Given this list of marker genes NEPNP, ROBO1, ASCL1, PXT1 (NCBI Gene Id 222659), CLEC4E, LELP1, TAFA4, CPB2, RPS29, KCNT1, IGHG3, ADAMTS16, DIMT1, EGR3, CCDC7, FABP6, TRHR, BCL2L10, HCK, ZP2, UBE2DNL (ubiquitin conjugating enzyme E2 D N-terminal like (pseudogene)), RNF138, HPCAL4, RETREG1, LRFN2, MIR211, FGFR4, COL6A6, SOHLH2, GASK1B, PLIN5, LIPH, RANBP10, SUGT1, PLA2G3, ARL10, CFAP100, CXCR1, NIBAN3, CFI, AGMAT, ASTN2, MAT2B, DNAAF10, MYO15A, RBP1, IL31, ZEB2, PRTG, GGT5, ZSWIM2, NTMT2, TMEM217, KCNV2, TMEM204, A1BG, MGAT3, PZP, UBAC1, FNDC5, FBLN2, PNPLA1, SULT1C2, HOXC12, PRKRIP1, SCGN, MYO18B, CCN5, PNCK (pregnancy up-regulated nonubiquitous CaM kinase), CSF2RBP1, DENND6B, FAM78B, COL6A1, CCDC136, IP6K3, SLC26A7, KIRREL3, COLEC10, MIR30D, ABCA5, KNDC1, COPZ2, LYG2, SARDH, UPP1, FIBIN, SYCE1, PTH2, UGGT2, RPH3A (rabphilin 3A), TMEM125, ELL3, MIR377, MEP1A, PODXL2, CHRM1, HOXA6, KCNJ5, CLDN19, SAA4, GPR101, UBE2Q2, HEBP2, CRIPT, OVOL3, CRYM, ZNRF1, NOTCH4 (notch receptor 4), GALR1, LRRC63, NDEL1, KRTAP5-1, MS4A7, TPRKB, PELI3, USP17L5, RGS17, SDSL, PKDREJ, HSD11B2, RAB18, TDRD12, TEKT1, CYP4X1, CTSG, SSBP1, PNMA3, GLIS3, ZIC4, here is a description of the gene set: Human Gene Set: GSE13522_WT_VS_IFNG_KO_SKING_T_CRUZI_Y_STRAIN_INF_UP To investigate the early host response triggered by three different strains of Trypanosoma cruzi at a local infection site, changes in host gene expression were monitored in a murine intradermal infection model using Affymetrix oligonucleotide arrays. Robust induction of IFN-stimulated genes (ISGs) was observed in excised skin 24 hours post-infection where the level of ISG induction was parasite strain-dependent with the least virulent strain triggering a muted IFN response. Infection of mice immunodepleted of IFNγ-producing cells or infection of IFNγ-deficient mice had minimal impact on the IFN response generated in T. cruzi infected mice. In contrast, infection of mice lacking the type I IFN receptor demonstrated that type I IFNs are largely responsible for the IFN response generated at the site of infection. These data highlight type I IFNs as important components of the innate immune response to T. cruzi the site of inoculation and their role in shaping the early transcriptional response to this pathogen. We used microarrays to detail the local host transcriptional response to intradermal T. cruzi infection in WT mice and mice depleted of NK cells, or deficient in IFN-gamma or type I IFN responses. Additionally we compared the local host-transcriptional response generated to infection with 3 different strains of Trypanosoma cruzi (Y, Brazil, and G). from publication Chessler AD, Unnikrishnan M, Bei AK, Daily JP, Burleigh BA (PMID 19201883) Genes up-regulated in skin after injection of Trypanosoma cruzi (strain Y): wildtype (BALB/c) versus INFG knockout. studied in species Homo sapiens